The following is a description of a gene set: Genes down-regulated in K562 cells (lymphoblast) by MYC in the presence of CKN1B. Inhibition of differentiation has been proposed as an important mechanism for Myc-induced tumorigenesis, but the mechanisms involved are unclear. We have established a genetically defined differentiation model in human leukemia K562 cells by conditional expression of the cyclin-dependent kinase (Cdk) inhibitor p27 (inducible by Zn(2+)) and Myc (activatable by 4-hydroxy-tamoxifen). Induction of p27 resulted in erythroid differentiation, accompanied by Cdk inhibition and G(1) arrest. Interestingly, activation of Myc inhibited p27-mediated erythroid differentiation without affecting p27-mediated proliferation arrest. Microarray-based gene expression indicated that, in the presence of p27, Myc blocked the upregulation of several erythroid-cell-specific genes, including NFE2, JUNB, and GATA1 (transcription factors with a pivotal role in erythropoiesis). Moreover, Myc also blocked the upregulation of Mad1, a transcriptional antagonist of Myc that is able to induce erythroid differentiation. Cotransfection experiments demonstrated that Myc-mediated inhibition of differentiation is partly dependent on the repression of Mad1 and GATA1. In conclusion, this model demonstrates that Myc-mediated inhibition of differentiation depends on the regulation of a specific gene program, whereas it is independent of p27-mediated cell cycle arrest. Our results support the hypothesis that differentiation inhibition is an important Myc tumorigenic mechanism that is independent of cell proliferation. Human Gene Set: ACOSTA_PROLIFERATION_INDEPENDENT_MYC_TARGETS_DN from publication Acosta JC, Ferrándiz N, Bretones G, Torrano V, Blanco R, Richard C, O'Connell B, Sedivy J, Delgado MD, León J (PMID 18838534) species: Homo sapiens, and this is the list of marker genes: KLF6, POLD4, LMO2, CMTM6, DMTN, TOR4A, LCP2, GABRE, STIMATE, ARHGEF2, TAX1BP3, LYPLA2, KCNH2, CREM, RIT1, SLC48A1, ST3GAL2, RHOC, PEX6, NFE2, CBFA2T3, KYNU, SH3BP1, IRF4, KRT10, MYC, SLC2A3, LYL1, CSH2, ARFGAP3, CHST12, KRT8, CALB1, PTPRC, SIDT2, ID1, HBB, GTF2F1, SLCO2B1, BCAM, MIA2, TWNK, PIM1, SHC1, ALAS2, RHOG, CAPN1, NAGA, ADGRG1, ACRV1, TRPV2, ARL4A, MPP1, USP11, FAXDC2 (NCBI Gene Id 91674), RAC2, SHANK2, SNCG, MCL1, MINPP1, SEC14L1, LRP10, HOXD1, ADAMTSL4, RHCE, RHD, LASP1, TNNT1, ESR1, ACSM3, RAB5B, UGP2, MCAM, AKR1C1, EPOR, CAP1, SERPINH1, FDXR, SNPH, AQP3, CD63, CARD9 (NCBI Gene Id 64170), ADAM8, JUNB, ARHGEF5, CHPF2, TESPA1, YES1, GATA1, C11orf21, STAT3, RAB13, AMPD3, HMBS, NEU1, SELENBP1, AKR1C2, STAT5A (NCBI Gene Id 6776), ADGRE5, BCL2L1, CLEC11A, KRT18, SLC10A3, TNFAIP8, SAMSN1, AIF1, ITFG2, SEC24D, GDE1, MINK1, FADS1, CTSD, HEY1, ESYT1, GYPB, S100A11